Given this list of marker genes FAM184B, NABP1, ATP8B3, USP7, MINAR1, CNP, RBM43 (RNA binding motif protein 43), MIF, FANCM, CASP3, NACC2, MRPL17, SLFN13, RDH5, RNF214, FGF9, RNF213, NAB1, STAT1, NR4A3, PIK3AP1, RMDN3, P2RX4 (purinergic receptor P2X 4), HAT1, UBE2L6, TWIST1, FCF1, MAD2L1BP, ELOVL3, MOBP, ZAN, RFX4, DHX58, ADAMTS15, HOXD12, UBE2L3, TMTC2, USP37, PHLDA2, PDE3A, TMC5, UBL4A, SLF2, B4GALT5, GABRG1, SLC4A2, SAA2, SH3BP4, CDKN1A, RSPH9, RBBP8, PACSIN1, SNHG10, KCNC3, PLD3, SKOR1, ZNFX1, SMG7, DTX3L, CD83, EVC, KDR, TMEM238L, DOK7, SCRIB, ARHGAP8, LIMD1, SCNN1B, NEO1, NOTCH1, EHD4, ERP27, ZNF444, ALS2, CD69, MED9, TPX2, SH3GL3, GRB7, SERPINA3 (NCBI Gene Id 95022), NOD1, MYH3, SCARA3, PPARGC1B, COL5A1, MRPL55, LIPH, FZD4, SPRR2A, PNP, HPSE, NAA25, COMP, NLRX1, STARD3, RAP1B, IFI44, CLDN8, TXNDC17, TRIB1, ANKRD12, MT2A, ASIC3, EEPD1, HMOX2, CXCL9, SYNJ1, ZIC3, UPK3BL1, PSMA2, FN3K, PML, MED15, BCL2L14, HOOK2, PMP22, LRRC75B, COL6A2, ARC, ENO4, RPH3A (NCBI Gene Id 22895), GRAMD2B, ABTB2, NRIP3, SUSD5, DAXX, PPM1K, FBXO6, ALDH18A1, CDS1, NAB2, TRAFD1, ROCK1, ACOT7, SCN11A, GFPT2, DGKH, RGL3, FAM221B, UBR4, DDX24 (NCBI Gene Id 57062), SLC2A1 (solute carrier family 2 member 1), AARS1, ACOD1, MRAP, MX2, UGCG, SLC52A3, TICRR, ASCC3, PTPN5, EPHX2 (epoxide hydrolase 2), POPDC2, SLC16A8 (solute carrier family 16 member 8), IL12B, FLOT2, MAP3K12, HINFP, SHMT1, CSRNP1, SGCB (NCBI Gene Id 6443), POLD2, SIN3B, IL4R, DNAJA1, ESYT1, RAB3IL1, RAPGEF2, CASK, PLAAT3, LRATD2, CFAP251, HOXC6, ARHGAP10, DLGAP3, NFKBIB, DYRK1A, CCND2, HSPA2, SNX11, UPP1, CBLC, RIPK1, REXO1, SLC22A15, PLB1, SLURP1 (NCBI Gene Id 57152), C19orf12, SLIT2, MFAP5 (microfibril associated protein 5), NEU1, DDX4, TRIM14 (NCBI Gene Id 9830), SOWAHC, ZNHIT1, SCG3, LIPK, BATF2 (basic leucine zipper ATF-like transcription factor 2), TREML2, BRCA1, here is a description of the gene set: To obtain insight into the genetic basis of the increase of functional activity of memory B cells over time, we compared the gene expression profiles of day 7 and day 40 NP-specific/IgG1 memory B cells, GC B cells and plasma cells in immunized WT mice and naïve B cells, before and after activation in vitro. Human Gene Set: GSE11961_FOLLICULAR_BCELL_VS_GERMINAL_CENTER_BCELL_DAY7_DN studied in species Homo sapiens from publication Kaji T, Ishige A, Hikida M, Taka J, Hijikata A, Kubo M, Nagashima T, Takahashi Y, Kurosaki T, Okada M, Ohara O, Rajewsky K, Takemori T (PMID 23027924) Genes down-regulated in follicular B cells versus day 7 germinal center B cells.